The following is a description of a gene set: Human Gene Set: GOBP_REGULATION_OF_METAPHASE_PLATE_CONGRESSION studied in species Homo sapiens Any process that modulates the rate, frequency, or extent of metaphase plate congression, the alignment of chromosomes at the metaphase plate, a plane halfway between the poles of the spindle., and this is the list of marker genes: TTL, KAT5, KAT2B, SPAG5, SIRT1, BIRC5, NUMA1, CDK1, BECN1, DYNC1H1 (NCBI Gene Id 992), INCENP, AURKB, MAD1L1, CDCA8, HNRNPU